Given this list of marker genes BPGM, EPOR, EPO, HBA1, HBA2, EGLN1, HBB, HSCB (NCBI Gene Id 150274), JAK2, VHL, EPAS1, KLF1, SH2B3, here is a description of the gene set: Any deviation from the normal ratio of the volume of red blood cells to the total volume of blood. Abnormal hematocrit species: Homo sapiens Human Gene Set: HP_ABNORMAL_HEMATOCRIT